Given this list of marker genes Fzd3, Neurod4, Celsr1, Ascl1, Tbx20, Olig3, Phox2b, Celsr2, Celsr3, Dab1, Vegfa, Nrp1 (neuropilin 1), Reln, Ntn1, Lhx1, here is a description of the gene set: Mouse Gene Set: GOBP_MOTOR_NEURON_MIGRATION The orderly movement of a motor neuron from one site to another. A motor neuron is an efferent neuron that passes from the central nervous system or a ganglion toward or to a muscle and conducts an impulse that causes movement. species: Mus musculus